The following is a description of a gene set: Mouse Gene Set: REACTOME_EUKARYOTIC_TRANSLATION_ELONGATION Eukaryotic Translation Elongation species: Mus musculus, and this is the list of marker genes: Eef1g, Eef1d, Eef2, Eef1b2, Eef1a1